Given this list of marker genes Tent4b, Tent4a, Gmppb (GDP-mannose pyrophosphorylase B), Rngtt, Fpgt, Thg1l, Gdpgp1 (GDP-D-glucose phosphorylase 1), here is a description of the gene set: Mouse Gene Set: GOMF_GUANYLYLTRANSFERASE_ACTIVITY Catalysis of the transfer of a guanylyl group to an acceptor. species: Mus musculus